The following is a description of a gene set: studied in species Homo sapiens Vitamin A and carotenoid metabolism Human Gene Set: WP_VITAMIN_A_AND_CAROTENOID_METABOLISM, and this is the list of marker genes: ABCG8, SULT2B1, NPC1L1, SULT1A1, CYP26A1, RBP2, CD36, CYP26B1, ADH1A, BCO2, DGAT1, ALDH1A3, RDH12, RXRA, LRAT, RDH5, BCO1, ADH4, MAPK1, AWAT2, RARB, RDH8, LPL, RPE65, SCARB1, RLBP1, RETSAT, RBP1, RARA, CYP2E1, SDR16C5, ALDH1A1, RBP7, RXRG, ABCG5, DHRS3, CRABP2, CRABP1, RDH10, RBP4, RXRB (retinoid X receptor beta), ALDH1A2, RARG